The following is a description of a gene set: A mitotic cell cycle checkpoint that slows DNA synthesis in response to DNA damage by the prevention of new origin firing and the stabilization of slow replication fork progression. Human Gene Set: GOBP_MITOTIC_INTRA_S_DNA_DAMAGE_CHECKPOINT_SIGNALING species: Homo sapiens, and this is the list of marker genes: TIPIN, EME2, CHEK2, RAD9A, NEK11, FANCD2, MSH2, RAD9B, ATF2, XPC, HUS1B, HUS1, MDC1, MUS81, RAD17, EME1, MRE11